Given this list of marker genes SCRT2, CTBP2, CYB561A3, CDH13, ADAMTS1, SMARCC1, PURB, MYH9, RNF133, UBR3, TIMP2, FCHSD2, ZFP36, CSTPP1, MAT2A, PELI3, SERF2, AQP2, CSRNP3, PCNX2, BCL9 (BCL9 transcription coactivator), LDLRAD2, SELENOV, DYRK1A, COL24A1, SMARCAD1, PLAGL2, SH3PXD2A, BUB3, AKIRIN1, KDM1B, TSKU, FANCI, ARK2C, DERPC, C17orf58, CPEB3, SCN2B (NCBI Gene Id 6327), AKAP13, AFG3L1P, AMBRA1, GAB2, TMEM87A, MACROH2A2, FAM83D, KCNK7, UBE2O, PPME1, STC1, TBC1D9B, PNCK, LRRC14, HSD3B2, SLC44A1, DBN1, NPTX1, NCOA1, PFKFB2, B3GNT9 (UDP-GlcNAc:betaGal beta-1,3-N-acetylglucosaminyltransferase 9, NCBI Gene Id 84752), TRA2B, CPA4, UBE2W, NCDN, here is a description of the gene set: Genes having at least one occurence of the motif CAGGTCC in their 3' untranslated region. The motif represents putative target (that is, seed match) of human mature miRNA hsa-miR-492 (v7.1 miRBase). Human Gene Set: CAGGTCC_MIR492 species: Homo sapiens